The following is a description of a gene set: species: Mus musculus Regulatory CD4+ T cells (Tr cells), the development of which is critically dependent on X-linked transcription factor Foxp3 (forkhead box P3), prevent self-destructive immune responses. Despite its important role, molecular and functional features conferred by Foxp3 to Tr precursor cells remain unknown. It has been suggested that Foxp3 expression is required for both survival of Tr precursors as well as their inability to produce interleukin (IL)-2 and independently proliferate after T-cell-receptor engagement, raising the possibility that such 'anergy' and Tr suppressive capacity are intimately linked. Here we show, by dissociating Foxp3-dependent features from those induced by the signals preceding and promoting its expression in mice, that the latter signals include several functional and transcriptional hallmarks of Tr cells. Although its function is required for Tr cell suppressor activity, Foxp3 to a large extent amplifies and fixes pre-established molecular features of Tr cells, including anergy and dependence on paracrine IL-2. Furthermore, Foxp3 solidifies Tr cell lineage stability through modification of cell surface and signalling molecules, resulting in adaptation to the signals required to induce and maintain Tr cells. This adaptation includes Foxp3-dependent repression of cyclic nucleotide phosphodiesterase 3B, affecting genes responsible for Tr cell homeostasis. from publication Gavin MA, Rasmussen JP, Fontenot JD, Vasta V, Manganiello VC, Beavo JA, Rudensky AY (PMID 17220874) Cluster P2 of genes with similar expression profiles in peripheral T ymphocytes after FOXP3 loss of function (LOF). Mouse Gene Set: GAVIN_FOXP3_TARGETS_CLUSTER_P2, and this is the list of marker genes: Ccl5, Neurl3, Ifi202b, Tbx21, Gstt2, Chst15, Padi2, Sec61a2, 2610005L07Rik, Ctse, Bmp7, Lck, Itga4, Gja1, Mtmr9, Sanbr, Cd200r4, Gucy1b1, Peli1, Sigmar1, Foxn3, Airn, Pstpip2, Fam20a, Cxcr3, Cpm, Casp4, Otud4, Ldhd, Pex3, St6galnac1, Iqcc, Ifi44l, Firrm, Myo6, Vdr, Prr5l, 1700091H14Rik, Dsp, Igfbp7, Fcgr3, Ss18, Zfp869, Daw1, Cxcr5, Ly6k, Prickle1, Gemin5, Arsb, Cd7, Slc2a8 (solute carrier family 2, (facilitated glucose transporter), member 8), Kif23, Adat2, Crybg2, Cep192, 2510009E07Rik, Tmem38b, Pcm1, Sik1, Bambi-ps1, Mbnl3, Btg1, Nckap1l, Serpinb1a, Gm6934 (predicted gene 6934), Cd22, Ccl20, Tnfsf8, Ramp1, Bicc1, Txnl4a, Il17a, Galns, Eps15, Lime1 (Lck interacting transmembrane adaptor 1), Abcb1a, Slfn5, Tm6sf1, Klk1b22, Rgs11, Gaa, Tmem176b, Bcl2, Cpe, Ptger3, Rab6b